The following is a description of a gene set: Human Gene Set: ZHOU_CELL_CYCLE_GENES_IN_IR_RESPONSE_24HR Cell cycle genes significantly (p =< 0.05) changed in fibroblast cells at 24 h after exposure to ionizing radiation. The changes in global gene expression in response to DNA damage may derive from either direct induction or repression by transcriptional regulation or indirectly by synchronization of cells to specific cell cycle phases, such as G1 or G2. We developed a model that successfully estimated the expression levels of >400 cell cycle-regulated genes in normal human fibroblasts based on the proportions of cells in each phase of the cell cycle. By isolating effects on the gene expression associated with the cell cycle phase redistribution after genotoxin treatment, the direct transcriptional target genes were distinguished from genes for which expression changed secondary to cell synchronization. Application of this model to ionizing radiation (IR)-treated normal human fibroblasts identified 150 of 406 cycle-regulated genes as putative direct transcriptional targets of IR-induced DNA damage. Changes in expression of these genes after IR treatment derived from both direct transcriptional regulation and cell cycle synchronization. species: Homo sapiens from publication Zhou T, Chou J, Mullen TE, Elkon R, Zhou Y, Simpson DA, Bushel PR, Paules RS, Lobenhofer EK, Hurban P, Kaufmann WK (PMID 17404513), and this is the list of marker genes: CEP55, SQOR, TOPBP1, DCN, CCNB2, FBLN1, LBR, MCM8, HMGB3, PLEK2, PTTG1, MCM2, PARPBP, COLEC12, NUP88, EIF2S1, TPRKB, H2AZ2, SPAG5, PTTG2, GASK1B, EXO1, F10, KPNA2, TTK, WIPI1, SPC25, H2AX, CACYBP, BIRC5, CENPF, GPN3 (GPN-loop GTPase 3), RAD54L, TRIP13, MAD2L1, RFC5, DCTPP1, HMGB2, HAUS8, CLN6, ANLN, DEPDC1, DTYMK, DLGAP5, ODF2, LMNB1, CDC20 (NCBI Gene Id 991), KIF20A (NCBI Gene Id 94421), RFC4, UBE2C (NCBI Gene Id 11065), MCM3, PAICS, RPA2, KIF11, SULF2, MDC1, IFT20, BORA, DNAJC9, MCM7, SMC2, NCAPH2, GINS3, PTTG3P (pituitary tumor-transforming 3, pseudogene), EXOSC8, CSE1L, CMC2 (C-X9-C motif containing 2), JPT1, HMMR, CDKN3, CEP43, PCNA, FABP5, MTFR2, SEMA3B, UHRF1, TOP2A, POC1A, CDK2, ASPM, SOD3, CENPK, PRC1, CCNA2, KIF23, NUP107, NEK2, RBBP8, CENPN, TIMELESS, LRRN4CL, CDCA8, MXRA5, RANBP1, USP1, KNSTRN, POLD1, E2F8, FBXO5, NUF2, CHAC2, NASP, EZH2, NEIL3, TDP1, QSER1, BUB1, RACGAP1, CKAP2, CENPA, LXN, CDK1, SMPD4, PIMREG, KIF22, HAUS3, CCNB1, KIFC1, UBE2T, KNTC1, MYBL2, MAGOHB, LAMB1, ALYREF, MELK, NUSAP1, E2F1